Given this list of marker genes Neat1, Emb, Fuca1, Alox5ap, Eif3f, Ypel3 (yippee like 3), Pdcd4, Zmynd8, Niban1, Ramp1, Ccdc88c, Foxp1, Ifngr1, Klhl24 (NCBI Gene Id 98030), Ccrl2, Pid1, Stap1, Eef2, Fosb, Cybb, 9930111J21Rik2, Cox7a2l, Klf2, Tbc1d9, Uba52, Erp29, Btg2, Tent5a, Nfkbiz, Rgs2, Zfp36l2, Igsf6 (NCBI Gene Id 80719), Man2b1, Arl5c, Nsa2, Nop53 (NOP53 ribosome biogenesis factor), Gm2a, Itga4, Jun, Tsc22d3, Bri3, Arhgap9, Ptprc, Nfam1, Eif3h, Fos, here is a description of the gene set: from publication Cui A, Huang T, Li S, Ma A, Pérez JL, Sander C, Keskin DB, Wu CJ, Fraenkel E, Hacohen N (PMID 38057668) Cytokines mediate cell-cell communication in the immune system and represent important therapeutic targets. A myriad of studies have highlighted their central role in immune function, yet we lack a global view of the cellular responses of each immune cell type to each cytokine. To address this gap, the authors created the Immune Dictionary, a compendium of single-cell transcriptomic profiles of more than 17 immune cell types in response to each of 86 cytokines (>1,400 cytokine-cell type combinations) in mouse lymph nodes in vivo. A cytokine-centric view of the dictionary revealed that most cytokines induce highly cell-type-specific responses. For example, the inflammatory cytokine interleukin-1β induces distinct gene programmes in almost every cell type. A cell-type-centric view of the dictionary identified more than 66 cytokine-driven cellular polarization states across immune cell types, including previously uncharacterized states such as an interleukin-18-induced polyfunctional natural killer cell state. Mouse Gene Set: CUI_CDC2_IL33_RESPONSE_DN studied in species Mus musculus Genes negatively differentially expressed in cell type: cDC2 (conventional dendritic cell type 2) upon treatment with cytokine: IL-33 in mouse lymph nodes in vivo.